Given this list of marker genes TNS3, TNS4, MET, HGF, ITGB1, here is a description of the gene set: Human Gene Set: REACTOME_MET_INTERACTS_WITH_TNS_PROTEINS MET interacts with TNS proteins species: Homo sapiens